The following is a description of a gene set: Human Gene Set: GSE21927_UNTREATED_VS_GMCSF_GCSF_TREATED_BONE_MARROW_UP Genes up-regulated in CD11b BoneMarrow from BALBc mouse versus CD11b BoneMarrow from BALBc mouse incubated with GMCSF and GCSF. species: Homo sapiens from publication Marigo I, Bosio E, Solito S, Mesa C, Fernandez A, Dolcetti L, Ugel S, Sonda N, Bicciato S, Falisi E, Calabrese F, Basso G, Zanovello P, Cozzi E, Mandruzzato S, Bronte V (PMID 20605485) Tumor growth is associated with a profound alteration of myelopoiesis, leading to recruitment of immunosuppressive cells known as myeloid-derived suppressor cells (MDSCs). Analyzing the cytokines affecting myelo-monocytic differentiation produced by various experimental tumors, we found that GM-CSF, G-CSF, and IL-6 allowed a rapid generation of MDSCs from precursors present in mouse and human bone marrow (BM). BM-MDSCs induced by GM-CSF+IL-6 possessed the highest tolerogenic activity, as revealed by the ability to impair the priming of IFN- -producing CD8+ T cells upon in vivo adoptive transfer. Moreover, adoptive transfer of syngeneic, GM-CSF+IL-6-conditioned MDSCs to diabetic mice transplanted with allogeneic pancreatic islets resulted in long term acceptance of the allograft and correction of the diabetic status. Cytokines inducing MDSCs acted on a common molecular pathway. Immunoregulatory activity of both tumor-induced and BM-derived MDSCs was entirely dependent on C/EBP transcription factor, a key component of the emergency myelopoiesis triggered by stress and inflammation. Adoptive transfer of tumor antigen-specific CD8+ T lymphocytes resulted in therapy of established tumors only in mice lacking C/EBP in myeloid compartment. These data unveil another link between inflammation and cancer and identify a novel molecular target to control tumor-induced immune suppression. We used gene expression analysis to identify those factors, secreted by tumor-infiltrating MDSC, which could drive emathopoiesis. Moreover we compare gene expression profile of tumor-induced MDSC, obtained from either the spleen and the tumor infiltrate of tumor bearing mice, and in vitro bone marrow-derived MDSC., and this is the list of marker genes: LY86, STX10, AGPAT1, KIF27, SQOR, RFPL3S, PRMT9, BEST2, ZFP1, EPB41, VAV3, IRS2, RALGAPA1, ZMIZ1, JCHAIN, MAGEH1 (MAGE family member H1), STRADB (NCBI Gene Id 66009), TMEM68, FAM167A, RPF2, CRISPLD1, RFC3, RAD23B, ZNF608, AMOTL2, MRPL19, ADA2, LGALSL, HDHD2, RAC2, CNP, PAPSS1, ZBTB34, NAP1L3, CLYBL, ARL6IP1, PCA3, GFM1, EGR3, ASF1A, MAGOH-DT, CDH15, BEND3, SRRM2-AS1, CREG1, PTBP2, TOMM70, BBOX1, PRRC1, KDM1B, LINC00917, SLC7A7, C2orf42, ZSWIM7, SH3YL1, IL21R, TAS2R19, LINC01541, EPB41L5, LIPJ (NCBI Gene Id 142910), ALDH18A1, ING5, CNIH1, CCT4, NDUFB5, IL2, HMMR, PSMG3, PYM1, GMNC, CYB561D1, SUPV3L1, DPY19L3-DT, CAPZA2, ANXA4, RNF112, SKAP2, HHIP-AS1, SOX7, WFDC21P, DOCK7 (dedicator of cytokinesis 7), SP3, GYS1, OR7E87P, ZBTB10, COTL1, MTAP, PPAT, DHRS7B, JAZF1, TNFRSF21, RUNX1, PARK7, ASXL1, TNS3, FAM98B, TTC13, CARNMT1, AIMP2, AKR7A2, NREP, CBX6 (chromobox 6), DNAJB4, WDR12, N4BP2, ANAPC4, CLDN1, ERCC6L2-AS1, PARP16, WBP1L, ADCY3, TMEM218, POLR2H, RHOBTB1, ZNF570, GXYLT1, ZNF529, RSL24D1, TSEN15, AMN1, SLC38A10, OLA1, TMEM201, GCLC, LIPA, JAG2, R3HDM1, TMSB15B-AS1, ANLN, TAS2R7, UBE2G1, ACSL3, EED, LINC00487, NDFIP1, MTNAP1, TUBAL3, AXIN2, LRPPRC, ANKMY2, INKA2, PROSER2, DYRK2, NPEPPSP1, IWS1, ELP6, TGFB3, TMEM14C, TIFA, STK38L, SLC25A17, PAXIP1, PAXBP1, ARID3B, CSGALNACT2, FAM135B, H4C4, YY1, RNASEH2C (NCBI Gene Id 84153), CTPS2, MAPDA, C1D, PLCXD1, ATP13A3, GSPT2, AK3, RXYLT1, BTBD3, NBR1, SPMIP1, SLC15A4, FLT1, B4GALT5, STX2, ATF1, SOX4, TTL, SACS, PI15, DNAJA3, MAP6, KLHL14, SLC35F2, GK5, TMEM200B, H3-3B, ZNF385C, IFT20, WDR83OS, HMGN3, COPS2, PIWIL4, NIFK, LINC00665, LARP1B, C4orf46 (NCBI Gene Id 201725)